The following is a description of a gene set: A second wave of blood cell production that, in vertebrates, generates long-term hemopoietic stem cells that continuously provide erythroid, myeloid and lymphoid lineages throughout adulthood. species: Homo sapiens Human Gene Set: GOBP_DEFINITIVE_HEMOPOIESIS, and this is the list of marker genes: TAL1, GATA2, HOXA9, SP3, LYL1, SENP1, MEIS1, TGFBR3, KMT2A, TEK, GATA1, ZFPM1, CDK5RAP3, HOXB4, MFAP5, BCR, CBFB, ADAR, ZFP36L2, HIPK1, HOXB3